Given this list of marker genes BASP1, MEIS1, HOXA10, EIF3A, INHBA, SLITRK1, SPTBN1 (NCBI Gene Id 91654), ZNF521, NFIX, RBFOX2, MYCL, NAV1, SMARCA5, CDCA7, TIAM1, HMGB1, SFRP1, SOX4, ELAVL1, TRIM8, SYT4, DAB2IP, KLF3, CRMP1, OLFM1, NASP, SLIT2, RRM2, PCDH18, STMN1 (NCBI Gene Id 3925), RASSF2, CDC27, IGF1, TCF4, PUM1, FBLN5, COLEC10, NUDT3, ELAVL4, ETS1, CDK2 (NCBI Gene Id 1017), YWHAZ, ANKRD11, DDX6, PHF6, here is a description of the gene set: Predicted targets of SOX9 that are down-regulated during early prostate development. from publication Schaeffer EM, Marchionni L, Huang Z, Simons B, Blackman A, Yu W, Parmigiani G, Berman DM (PMID 18794802) Cancer cells differentiate along specific lineages that largely determine their clinical and biologic behavior. Distinct cancer phenotypes from different cells and organs likely result from unique gene expression repertoires established in the embryo and maintained after malignant transformation. We used comprehensive gene expression analysis to examine this concept in the prostate, an organ with a tractable developmental program and a high propensity for cancer. We focused on gene expression in the murine prostate rudiment at three time points during the first 48 h of exposure to androgen, which initiates proliferation and invasion of prostate epithelial buds into surrounding urogenital sinus mesenchyme. Here, we show that androgen exposure regulates genes previously implicated in prostate carcinogenesis comprising pathways for the phosphatase and tensin homolog (PTEN), fibroblast growth factor (FGF)/mitogen-activated protein kinase (MAPK), and Wnt signaling along with cellular programs regulating such 'hallmarks' of cancer as angiogenesis, apoptosis, migration and proliferation. We found statistically significant evidence for novel androgen-induced gene regulation events that establish and/or maintain prostate cell fate. These include modulation of gene expression through microRNAs, expression of specific transcription factors, and regulation of their predicted targets. By querying public gene expression databases from other tissues, we found that rather than generally characterizing androgen exposure or epithelial budding, the early prostate development program more closely resembles the program for human prostate cancer. Most importantly, early androgen-regulated genes and functional themes associated with prostate development were highly enriched in contrasts between increasingly lethal forms of prostate cancer, confirming a 'reactivation' of embryonic pathways for proliferation and invasion in prostate cancer progression. Among the genes with the most significant links to the development and cancer, we highlight coordinate induction of the transcription factor Sox9 and suppression of the proapoptotic phospholipid-binding protein Annexin A1 that link early prostate development to early prostate carcinogenesis. These results credential early prostate development as a reliable and valid model system for the investigation of genes and pathways that drive prostate cancer. species: Mus musculus Human Gene Set: SCHAEFFER_SOX9_TARGETS_IN_PROSTATE_DEVELOPMENT_DN